Given this list of marker genes ICOS, SLC2A6, ZCCHC12 (NCBI Gene Id 257051), PPT2, CYP1B1, NEURL2, IL5, CCL20, HSD3B1, IL15RA, C22orf23, IL20RA, PSMC2, KBTBD4, GBP4, SFRP5, SYN1, NRROS, PARP9, IGKC, CD8B, ZHX2, GJC2, CPEB3, CISH, PAQR8, F8, AKT3, GPR151, CTLA4, PCDHB6, NECTIN3, PNPT1, ADRA1A, CERS4, KRT1, IGSF8, HSPA5, TBX15, DNAJA2, ECSCR, CD40, DDR2, MS4A18, NF1, ZNF444, CCL4, TLCD1, ARMC2, OAS1, ISL1, SEMA6D, B4GALNT2, KRTAP19-3, TLR9, PRPH, TMCC3, FCRL1, ADGB, THADA, PPA1, SAMD9L, CHMP5, BVES (NCBI Gene Id 11149), DNM3, NAV2, FAM89A, JAK2, MX1, FGF22, CSGALNACT1, MR1, C4orf51, NPHS1, DNMT3L, BRSK2, PRKCQ, RNF114, C19orf12 (chromosome 19 open reading frame 12), TMEM266 (transmembrane protein 266), OTOP2, WDR1, GTF3C6, PIGV, PSMB11, ZBP1, EHD4, OPRM1, PAX5, SLC25A34, TUBGCP4, SUSD2, ADPRM, GADD45B, PSMA5, EBF3, TPX2, UBA1, CKM, SGCB, RTKN, TMEM104, CCNB3, ZDHHC11, COL24A1, KNL1, FSTL5, NIBAN1, PRKAG3, GPR143, SOBP, MYO1E, GLT8D2, BMPR1A, CAPN11, GFM2, NDRG4, PRLR, FKBPL, COX7B2, TSNAXIP1, SERPINB9, LDAF1, ANGPT4, APOBEC1, TNFRSF25, INPP5B, LYNX1, ILDR1, PRAMEF2, SLFN13, GARIN2, RAB11FIP4, RASGRP1, UNC5B, CBX5, TCEA2, ETNK1, HEATR5B, GPR63, LOXL1, SNX2, ISG15, TFAP2E, STAU2, GPR152, HIVEP3, CYP4B1, MAMLD1, EPB42, SLFN12, RNGTT, ALCAM, TUBE1 (NCBI Gene Id 51175), PEA15, SLC16A10, FAM110D (family with sequence similarity 110 member D), ATF3, SEC23B, STAP1, NPHP4, SUB1, GPR135, EPCAM, CMPK2, ETV6 (ETS variant transcription factor 6), RBL1, MMP13, ATP10B, IL10, IFITM5, ZNF475, PRKAA2, ELOVL3, CD300LD, ZSCAN12, CCDC73, CFAP184, RNF32, PDP2, SLC25A27, MFHAS1, ERN2, GFI1B, CCND2, MIR124-1HG, ZC2HC1C, TMEM121B (NCBI Gene Id 27439), MROH9, PDZK1, INHBC, ARIH2OS, UEVLD, CFAP52, PLXNC1, UBR4, KCNN3, IFNB1, SHC4, RFX5, here is a description of the gene set: from publication Ochiai K, Maienschein-Cline M, Simonetti G, Chen J, Rosenthal R, Brink R, Chong AS, Klein U, Dinner AR, Singh H, Sciammas R (PMID 23684984) species: Homo sapiens Temporal analysis of B cell activation in vitro using CD40L and IL-2/4/5 cytokines in wild type Irf4+/+ B cells or in mutant Irf4-/- B cells harboring a tet-inducible allele of Irf4. IRF4 expression was restored, or not, in the Irf4-/- background by culturing in the presence of low or high concentrations of doxycycline. The results provide insight in the role of IRF4 expression levels in coordinating different programs of B cell differentiation. Human Gene Set: GSE46606_IRF4HIGH_VS_IRF4MID_CD40L_IL2_IL5_DAY1_STIMULATED_BCELL_DN Genes down-regulated in CD40L and IL-2 IL-4 IL-5 stimulated at day 1 B cell IRF4high versus CD40L and IL-2 IL-4 IL-5 stimulated at day 1 B cell IRF4intermediate.